The following is a description of a gene set: Human Gene Set: REACTOME_DEGRADATION_OF_DVL studied in species Homo sapiens Degradation of DVL, and this is the list of marker genes: PSMC5, PSMD11, PSMB7, PSMA1, DVL2, DVL1, KLHL12, PSMB6, DACT1, SEM1, PSMD3, PSMA5, PSMC1, PSMA2, UBC, ADRM1, PSMD12, PSMD8, PSMB3, PSMC4, PSMA3, PSMD1, DVL3, PSMA7, PSMC3, PSMD2, PSMB1, RPS27A, PSMB2, UBA52, PSMD13, PSMD14, CUL3, PSMD6, PSMC2, PSMA6, HECW1, RBX1, PSMB4, UBB, PSMC6, PSMB5, PSMA4, PSMD7